Given this list of marker genes UNC13A, ITSN2, SYT2, SYT1, PLAA, CPNE5, SYT17, SYT14P1, CPNE9, SYT4, SMURF1, CPNE6, NEDD4L, SLC23A2 (solute carrier family 23 member 2), RASAL1, RIMS1, MUL1, CACNG7, RNF157, RIMS2, PRKN, SYT3, here is a description of the gene set: Any process that activates or increases the frequency, rate or extent of dendrite extension. studied in species Homo sapiens Human Gene Set: GOBP_POSITIVE_REGULATION_OF_DENDRITE_EXTENSION